The following is a description of a gene set: Reactome Pathway: Lysine catabolism part of: Metabolism of amino acids and derivatives This event has been computationally inferred from an event that has been demonstrated in another species.<p>The inference is based on the homology mapping from PANTHER. Briefly, reactions for which all involved PhysicalEntities (in input, output and catalyst) have a mapped orthologue/paralogue (for complexes at least 75% of components must have a mapping) are inferred to the other species. electronically inferred by orthology from the curated human pathway studied in species Mus musculus, and this is the list of marker genes: Slc25a21, Phykpl, Hykk, Aadat, Dhtkd1, Aass, Pipox, Dlst, Dld, Crym